The following is a description of a gene set: Human Gene Set: GOCC_SEMAPHORIN_RECEPTOR_COMPLEX A stable binary complex of a semaphorin and a plexin, together forming a functional semaphorin receptor. species: Homo sapiens, and this is the list of marker genes: PLXNB3, PLXNA1, PLXNB2, PLXNA3, PLXNC1, PLXND1, PLXNA2, NRP1, TREM2, PLXNA4, NRP2, PLXNB1, SEMA4D (semaphorin 4D), ERBB2